Given this list of marker genes SIX2, H4C5, RPL35A, SHH, RPS27, RNF2, ADAT3, PIGO, GP1BB, LZTR1, TFAP2A, SOST, NIPBL, TRRAP, ZEB2, KIAA0753, LRPPRC, PRR12, OSGEP, GLE1, TCF12, NSRP1, B3GLCT, GPC3, SEPTIN9, DVL3, HNRNPK, B9D1, RSRC1, MICU1, BANF1, CDC42, ALDH6A1, SPRY4, PLAA, CTU2, MAF, CDC45, COL27A1, CCNK (NCBI Gene Id 8812), BBS12, FOXH1, PLEC (NCBI Gene Id 5339), ACBD6, GPC4, NXN, GNRH1, QARS1 (glutaminyl-tRNA synthetase 1), CD79B, KDM5A (NCBI Gene Id 5927), DYNC1I2, HIRA, CSGALNACT1, RPL18, NCDN, PIGU, CACNA1C, PPP1CB, NDP, ADGRG6, FANCG, TPM3, UHRF1, DPYSL5 (NCBI Gene Id 56896), FAR1, KCNK4 (potassium two pore domain channel subfamily K member 4), TGFB2, BRCA2, ALG9, BRIP1, SUPT16H, H4C3, FANCE, RPS28, ALX1, CASK, DCPS, PPP1R12A, FLNB, SLC12A6, GJA5, POLD1, MID1, STRADA, RPS24 (ribosomal protein S24), SHOC2, TDO2, FOXC1, ZMPSTE24, MED25, SOX6, PAICS, SETD1A, TTC7A, FMR1, FLNA, SH3BP2, PRPS1, EPB41L1, TMEM216, FBXL4, SHPK, NBAS, TWIST2, KMT2E, MYH11, CDH1, CSNK2A1, TUBA1A, NODAL, COA3, FAT4, PDGFRB, AP3B2, TCIRG1, CILK1, SLC2A10, GPKOW, PRKACB, RPL31, MAP2K1, LIG4, TTI2, TLK2, ALDH18A1, HERC1, FRA10AC1, ACY1, ITGA3, KIF15, SETD2, TMEM53, NHLH2, GATA5, ROR2, YRDC, NEB, JARID2, BAP1, RUNX2, TMEM231, NPHP1, FILIP1, BBS5, ARID1B, GFRA1, SMARCE1, PDPN, RB1, SLC1A4, PEX2, MIPEP, MED12L, LRRC8A, H4C9, MUSK, APC, IFT52, PIGN, ADAMTS3, PPP2R5D, MTX2, DISP1, TAFAZZIN, P4HB, LIFR, RAI1, EMC1, MAP2K2, KCNQ1OT1, ALPL, PRKAR1A (NCBI Gene Id 5573), CCND2, EVC, HHAT, SETBP1, ALG6, HBA2, STAMBP, CDKL5, CNOT1 (CCR4-NOT transcription complex subunit 1), TGDS, PITX1 (NCBI Gene Id 5307), CUX1, HELLS, GJA1, RNU12, IGF2, TMEM94, TMEM138, TAF1, OGT, FGF17, RAPSN, GNRHR, COX5A, RUSC2, RSPO2, PRTN3, SCN4A, AGL, GLYCTK, IQSEC2, CC2D2A, ATAD3A, BBS10, PLK4, RPS6KA3, ASCC3, SPEN, ZFX, EBP (NCBI Gene Id 139151), ABCA12, RAP1B, ADA2, ESCO2, TRIO, AARS1, AGA, MSL3, SLC9A6, CTNND1, TGFBR2, DDR2, CENPJ, HYMAI, FANCM, SMCHD1, AIFM1, HIVEP2, DVL1, WARS2, PAX3, GATA2, CRIPTO, RPS29, CAMK2B, IFT172, RPL27, EXOSC2, POU4F1, BBS9, CHRNG, OPHN1, FOXE1, RPGRIP1, TRIM37, TCTN1, WDR19, TONSL, FREM1, ZBTB20, SHANK3, ELN, RPL5, ATN1, NFIX, DPH5, PAH, HPDL, PAFAH1B1, HACE1, WDR26, RPS19, ZSWIM6, EXTL3, PDHX, TBX15, CEP19, PLAGL1, RIT1, TMEM147, DHCR7, TGFBR1, XYLT1, PRDM13, BLTP1, FRAS1, MED13, NTRK1, SEMA3E, SPOP, AXIN1, POLR1A, GON7, COG4, MACF1, LBR, STAT3, ZMIZ1, ZC4H2, NOTCH2, DHX9 (DExH-box helicase 9), PIK3R1 (phosphoinositide-3-kinase regulatory subunit 1), SEC23A, PTPN11, MAD2L2, ITGA8, EXT2, ACTA1, USB1, MSTO1, KMT2D, MED27, WDR73, CHRND, COX14, COLEC10, CRPPA (CDP-L-ribitol pyrophosphorylase A), CHD3, TOGARAM1, PTRH2, COX8A, HDAC4, TBCD, SIX3, SOS2, EBF3, ZFPM2, BBS1, KCNJ6, STAG2, DPM1, XRCC2, GATA1, POR, CYP27A1, NGLY1, CREBBP, GLI2, DNMT3A (DNA methyltransferase 3 alpha), SLC25A24, FBXO31, GNE, RPL15 (ribosomal protein L15), KATNB1, FANCI, SNRPN, NIN, GK, TSHR, NRAS, THRA, INTU, FOXE3, TMEM107, GRIP1, PRKDC, PEX6, EVC2, ZNF292, OFD1, PTDSS1, SEC24C, NALCN (sodium leak channel, non-selective), HEATR3, BBIP1, RPL35, ABCC9, NELFA, RAD51C, PRORP, AHDC1, SMG9, SPART, NSUN2 (NCBI Gene Id 54888), TRIM8, RAB34, PSMD12, MAN2B1, UFC1, DNAJC21, SMAD2, MYCN, SALL4, LMNB1, HSD17B4, IL6ST, FGFR2, TCOF1, FLII, INTS11, TSR2, BCR, ERCC4, FUCA1, LUZP1, WDR11, HS2ST1, NTNG2, POLR3A, RELN, POLR2A, GJA8 (NCBI Gene Id 2703, gap junction protein alpha 8), NSMF, TBR1, CLCN7, RERE, NOTCH3, RRAGC, CAPRIN1, DPH2, LEMD2, BBS4, DPF2, XYLT2, BPTF, HECTD4, BCL11B, RPS17, DPYD, PIGW, SPRED2, CHST14, CDKN1C, CASZ1, DDX59, KIF26A, H3-3A, KAT6B, INTS8, DNA2, FIBP, YARS1, CCBE1, ODC1, CHD4, CNOT3, IFT140, MED12, RNU4-2, ALX3, RRAS2, FAM20C, DCLRE1B, DOCK6, LZTFL1, PLCH1, KCNH1 (NCBI Gene Id 8656), TGFB3, UMPS, CNTNAP2, TBX2, SSR4, SPIN4, FOXP2, POU1F1, RAD51, MARS2, KCNJ5, SKIC2, MMP2, NEK1, EZH2, DEF6, CAMK2A, NFASC (NCBI Gene Id 23114), CENPF, ADNP, KCNJ2, KIDINS220, SLC18A3, CIT, SMPD4, CHN1, HLA-DPB1, AGO2, LEMD3, MAD1L1 (mitotic arrest deficient 1 like 1), BBS2, AFF3, FAM149B1, WASHC5, MLXIPL, TMEM67, LYN, WNK3, KBTBD13, ADK, KAT6A, HNRNPH2, RPL26, UGDH, ALK, MAPK1, UBE2T, RMRP, ERCC3, TRMT10A, KMT2B, NSD2, UBAP2L, TMEM237, NEDD4L, KLHL41, PRUNE1, FANCF, AP3D1, ACTL6B, SCN1A, NR4A2, MAGEL2, SLC9A7, TAF4, BRCA1, DHX37, NONO, PRDM16, PUM1, CCDC22, ZNF526, PROKR2, CDK10 (NCBI Gene Id 8558), MED13L, PTPN22, RAC3 (Rac family small GTPase 3), TRIP4, ASXL1, ERI1, TAOK1, KRAS, TERT, ATXN3, MARS1, FARSB, UFD1, CPLANE1, ABL1, COL25A1, MMP23B, TRIM32, SMARCA2, ANTXR1, CHST3, ATP6V1B2, LTBP1, MYH3, UBR7, PEX1, LRP5, SATB2, ARVCF, RPS10, COG1, PMM2, BUB1B, SOS1, KDR, PUS7, SLC35A1, ITCH, H4C11, EFNB1, IDUA, SCYL2 (NCBI Gene Id 55681), AASS, HID1, EP300, B4GALT1, STIM1, PDZD8, SMC1A, KIFBP, BMPR1A, CDC42BPB, INPPL1, LRP4, PIGL, UBE2A, SDCCAG8, ZMYND11, B3GAT3, CHRNA1, ASXL2, COL11A2, PIGA, ATP6AP1, DDB1, RPL9, NGF, RPS26, LMBR1, CRIPT, TBC1D24, PTEN, LRP2, PLOD3, ORAI1, SIN3A, CHRNA7, STIL, SCLT1, B9D2, POLR1D, TBCK, SIAH1, NUP88, DYRK1A, DNM1L, SNAP29, SRC, KISS1, AP1G1, MEIS2, CD79A, OSTM1 (NCBI Gene Id 28962), SIK3, VANGL2, DUSP6, PARS2, EED, PDCD6IP, DEAF1, MASP1, MTHFR, ERCC2, PDE6D, TXNDC15, RNU4ATAC, CEP290, POLR3GL, PPP2R1A, NKX2-5, BGN, WAC, DICER1, SLC26A2, ZMYM2, FIG4, SUFU, RYR1, POLR1B, GLB1, MEG3, TARS1, FLT4, SRCAP, KNSTRN, DNMT3B, VPS35L, SLC4A10 (solute carrier family 4 member 10), SMS, POLRMT, PGAP2, CDK13, MYT1L, ANKRD17, EFEMP2, TBC1D20, ALX4, RBL2, MAPRE2, IFT81 (intraflagellar transport 81), SLC32A1, GALNT2, PIK3CD, FGF20, DEPDC5, PYCR2, MKKS, TRAPPC9, NSD1, OCRL, THRB, DLX4, GNB2, FARSA, HNRNPC, ZBTB24, IPO8, SPI1, ASPM, SLC37A4, GDF1, RTTN, TCF4, EXOSC9, SRD5A3, PEX3, SKI, CLCN6, SLC29A3, MN1, GRIA3, DBR1, ZNF699, PRMT7, CTNND2, RREB1, ACBD5, TWIST1, VAC14, HLA-DPA1, HEY2, PAK1, AUTS2, ALMS1, STAG1, HYLS1, GAS1, KCNMA1, PIGY, BMPER, KCNQ1, TPR, GTF2H5, TAC3, DOK7, RNF113A, RBM10, TRIP13, RFWD3, ATRX, ACTG1, SCNM1, CRKL, RSPRY1 (ring finger and SPRY domain containing 1), TFAP2B, MRAS, KDM5C, MBD5, FBXO11, LOX, SLC39A13, CCDC32, GATA4 (NCBI Gene Id 2626), AFF4, GBA1, PLP1, INSR, RPS15A, HS6ST1, QRICH1, EHMT1, AKT3 (NCBI Gene Id 26068), PHIP, LMO1, CLP1, EIF5A, IL11RA, MTOR, CACNA1G, CDK5RAP2, HDAC8 (histone deacetylase 8), PKDCC, TASP1, ANAPC7, PPP1R21 (protein phosphatase 1 regulatory subunit 21), SOX9, IGLL1, GGT1, IFT74, ACOX1, PAK3, CTCF, RPL8 (NCBI Gene Id 6132), BCAS3, PIK3CA, COMT (catechol-O-methyltransferase), CPLX1, PACS2, GATAD2B, SMARCB1, PI4K2A, PLCB3, FLCN, BRAF (NCBI Gene Id 673), ATP6V1A, RAB23, TBCE, CCDC47, OTUD5, MYD88, JMJD1C, GLI3, PROK2, ZNF668, RTL1, HUWE1, WDR37, CDK19, CDCA7, FH, NAA10, CLCN3, ERMARD, PUF60, TRPM3, AP4S1, MOCS2, CBL, IFT27, SEMA5A, SPRED1, RAF1, THOC2, MRPS14, EDEM3, IGHM, RPS7, EXOC2, PDGFB, TENM3, MOCS1, GRIN1, SLC25A12, COL11A1, ALKBH8, TCTN3, AMER1 (NCBI Gene Id 160176), TXNL4A, COL1A1, SLC35C1, CDH11, NF1, MAP3K7, FGF8, IARS2, FGF3, CFAP418, KCNAB2, KIF21A (NCBI Gene Id 80819), RHOBTB2, MYPN, POLA1, TRAF7, SPTBN1, COL1A2, POC1A (POC1 centriolar protein A), HSPG2 (NCBI Gene Id 7796), THSD4, MAN2C1, BRPF1, CRELD1, FOCAD, POGZ, KREMEN1 (kringle containing transmembrane protein 1), PPP2CA, KAT8, PDE4D, JAG1, HS6ST2, NRCAM, PIK3R2, NOVA2, FGD1, MAT2A, CEP57, TCF20, PIEZO2, PIGV, FANCA, ABCD4, AKT1, P3H1, TPM2, BNC2, CDH2, HBA1, COG3 (component of oligomeric golgi complex 3), BLNK, ERF, SMAD3, MSX2, LTBP4, FANCL, SLX4, RRAS, GREB1L, PYCR1, NF2, DSE, SCAPER, WDR4, COL2A1, WNT5A, CNTN1, IFT56, FZD2, KPTN, PHF6, AVP, CTLA4, NSMCE3, ADAMTS10, BRCC3, FGFR3, ATP6V1E1, PRKCZ, TCTN2 (tectonic family member 2), IRF4, CARS1, NUP133, MYOD1, FGFRL1 (NCBI Gene Id 54966), BCORL1, ZIC3, PLAAT3, UBE3A, UBE4B, KMT2A, SEC24D (NCBI Gene Id 9871), SMAD4, WDR35, TTC8, SUOX, RPS20, ASNS, TOPORS, CDON, DDX6, SPECC1L, MEF2C, MGAT2, FKBP14, LIN28B, PEX5, CHD8, LETM1, KNL1, GNPTAB, MAN1B1, MAFB, ARCN1, ADAMTS15, GNPNAT1, BMP2, SMARCD1, HEPACAM, MKS1, UBE3B, CRB1, LAS1L, KCTD1, FLI1, GPT2, NAA60, FGF9, HMGA2, MITF, PTCH2, RECQL4, KDM6A, SET, TBX4, SRRM2, CEP120, DIS3L2, BBS7, SERPINH1, ZBTB18, ZIC1, BRD4, THSD1, B4GALT7, PITX2, RET, TP53RK, FBN1, GAD1, PACS1, RECQL, EPG5, FAM111A, ZPR1, GABRD, KCNN3, ASXL3, FN1, BMP4, USP9X, COX7B, NARS1 (NCBI Gene Id 9243), FOXP1, LMNA, DLK1, WASF1, SLC45A1, SMO, ANK1, ERCC1, TELO2, RPGRIP1L, ALG1 (NCBI Gene Id 56052), SLC39A14, TACR3, ASH1L, FANCD2, SPINT2, HRAS, ZIC2, CSPP1, FANCB, TRIP12, IL1RAPL1, CAMTA1, THUMPD1, THOC6, VSX1, DCHS1 (NCBI Gene Id 8642), KLF13, YWHAE, PIGG, SH2B1, TBX1, CANT1, ELMO2, TMCO1, NDE1 (nudE neurodevelopment protein 1), LAGE3, GORAB, ARL6, FREM2, SLC39A7, CHD7, PPP3CA, EEF1A2, ATP6V0A2, ANKRD11, PTH1R, ACTB, RPL11, ACTA2, RIPK4, KATNIP, C12orf57, FGFR1, TFE3, KISS1R, SON, PHOX2B, NKX3-2, GTF2E2, XRCC4, MCTP2, ALG13, PCLO, ARNT2, NLRP3, COL5A1, PRRX1, PGAP3, INTS1, OTX2, CTBP1, GNS, NKX2-6, MAPK8IP3, IFT122, WNT9B, DHPS, ERCC8 (ERCC excision repair 8, CSA ubiquitin ligase complex subunit), WBP4, CKAP2L, CHSY1, TBL1XR1, TNFRSF11A, SH3PXD2B, PHACTR1, AP1S2, PSMB8, GPAA1, IFT43, MYLK, FOXF1, HECW2, CRTAP, RASA2, VPS51, PIGB, IRX5, RAB3GAP1, TGFB1, CTSK (NCBI Gene Id 1513), FANCC, ERGIC1, PEPD, B3GALT6, KIAA0586, ANKH, GATA6 (NCBI Gene Id 2627), MPLKIP, BPNT2, PUS1, KIF7, SYNGAP1 (synaptic Ras GTPase activating protein 1), TCF3, HNRNPU, KDM1A, MEGF8, PPP1R15B, TAPT1, KANSL1, SUZ12, DLL1, GSC, TUBB, COL3A1, DDX3X, TPRKB, DPH1, RAD21, IGF1R, NAA80, BICRA, RARS2, PALB2, CITED2, COG8, EIF2AK3, ALG8, PGAP1, PTCH1, TGIF1, PRKAR1B, MFAP5, POLR1C, SKIC3, COLEC11, ZNF462, RLIM, PPIB, RAB3GAP2, RAP1GDS1, PRKG1, LARP7, ERCC6, WDPCP, NUP107, PSAT1, RALGAPA1, PHGDH, DPM2, here is a description of the gene set: studied in species Homo sapiens An abnormality in the placement of the ocular globe (eyeball). Abnormality of globe location Human Gene Set: HP_ABNORMALITY_OF_GLOBE_LOCATION